Given this list of marker genes Pikfyve, Dnajc2, Gcc2 (NCBI Gene Id 76266), Lpp, Ets1, Me2, Cnpy2, Txlna, Nr4a2, Shkbp1, Nectin1, Nolc1, Psmd12, Rad23a, Cdc37l1, Psmb2, Ankhd1, Bcl2l1, Fryl, Baz2b, Aktip, Zbtb11, Csnk1a1, Mydgf, Dzip1, Hdac4, Wasf2, Tjp2, Id2, Dnajb11, Notch1, Ptprj, Septin10, Ctbp1, Slc8a1 (NCBI Gene Id 319418), Psmc4, L3hypdh, Llph, Dis3, Plet1, Prr13, Cemip2, Krt19, Gata2, H4c8, Dnajc1, Nucks1, Bcl7a, Ptgfrn, Trim8, Tbc1d17, Mettl3, Dek, Rnd3, Cspg5, Zfp704, Tax1bp1, Elovl5, Hnrnpa0, Chd1, Plin3 (perilipin 3), Tob2, Rfwd3, Slc39a10, Col23a1, Oard1, Gm5176, H4c1, Id1, Cd2bp2, Ldb2, Pde3a, Rsrc1, St13, Camk1d, Upk2, Hcfc1r1, Upk3a, Aamp, Kdm3b, Oxct1, Chd4, Atp5me, Psmd2, App, Trim17, Uxs1, Map7d1, Ncor1, Emc1 (ER membrane protein complex subunit 1), Sipa1l2, Gon4l, Dhx36, Sfpq, Fam171a2 (family with sequence similarity 171, member A2), Tnks1bp1 (tankyrase 1 binding protein 1), Hypk, Zfp462, Nav1, Golim4, Wnk1, Mgst3, Arid5b, Zfp937, Sp6, Timp2, Ndufa4, Furin, Septin9, Litaf, Zbtb14, Snw1, Sox9, Aph1a, Phf13, Dctn4, Fat4, Vps36, Arhgef2, Lactb, Gigyf2, Ube2i, Alyref, Ptk7, Bckdha, Orai3, Sptbn1, H2ac18, Dusp7, Aftph, Dnmt1, Nlgn3, Rbms3, Cldnd1, Glmp, Lima1 (LIM domain and actin binding 1), Rnf111, Tbc1d16, Gpd2, Nrip1, Ciao2a, Pkp4, Bcl9, Fras1, Sart1, Gnai2 (G protein subunit alpha i2), Parva, Ly6h, Nfia, Pfdn2, Ptpn11, Phb1 (prohibitin 1), Micu2, Epha7, Hgs, Fgfr1op2, Smtnl2, Gadd45g (growth arrest and DNA-damage-inducible 45 gamma), Bclaf1, Cyp2f2, Klhdc10 (kelch domain containing 10, NCBI Gene Id 76788), Lrp1, Atad2b, Cdc27, H4c14, H3f5, Wwc1, Ppp4c, Dnmt3a, Cltc, Cldn7, Senp2, Dolpp1, Eif3j1 (NCBI Gene Id 98779), Gm4750, Nek7, Zmynd8, Scand1, Srsf9, Hspa8, Kbtbd2 (kelch repeat and BTB (POZ) domain containing 2), Ptms, Phkg2, Khdrbs3, Cald1, Tcf3, Tnrc6b, Smg6, Taf1, Phf6, Aldh1a1, Anxa9, Csrp1, Dync2i1, Rcor1, Wnt6, Gsr, Cuta, Ptges3, Ssh1, Ppil1, Derl1, Ablim1, Rest, Rangap1, Pfn1, Prrc2c (proline-rich coiled-coil 2C), Dpysl2, Ier5l, Hoxa13, Sap30, Slc38a10, Zfp664, Gria4, Kdm6b, Flnc, Kcnk1, BC048507, Itgb1, Set, Ppp2r5e, Rn18s-rs5, Atp1b1, Lratd2, Poldip3, Bsdc1, Trp53, Zfp110 (NCBI Gene Id 97420), Ptgr1, Prkcsh, Crim1, Triobp, Eif4a-ps4 (eukaryotic translation initiation factor 4A, pseudogene 4), Chpt1, Tlk1, Maged1, Adam17, Cxadr, Bahcc1, Zfp871, Fscn1, Sppl3, Rfx7, Pcdh18, Manf, Plcxd3, Nedd4, Nudt3, Klf3, Gsg1l, Pdzd2, Adamdec1, Pcnx3, Crebbp, Sin3b, Rhob, Dhx29, Tnrc6a, Arpc4, Kras, Hsd17b7, Aldh3b2, Rc3h2, H2ac4, Ubfd1, L3mbtl3, Nol8, Dazap1, Gpc1, Pabpn1, Clic4, Uhrf1, Bmp4, Hmg20b (high mobility group 20B), S1pr3, Wac, Vps54, Maco1, Arf3, Ago2, Septin7, Ywhae, H2aj, Ppp1ca, Sf3b2 (splicing factor 3b, subunit 2), Auts2, Pex5, Gtf2h3, Timm17b, Nufip2, Clptm1, Cdk14, Mia2, Kmt2c, Cdk2, Id3, Prrx1, Zc3h13, Cep170b, Rbm27, Mprip, Cables2, Btg1, Arhgdia (Rho GDP dissociation inhibitor alpha), Rnf122, Marchf7, Ncoa6, Shtn1, Dhrs3, AA986860 (expressed sequence AA986860), Ddx6, Canx, Zfp628, Sdf2l1, Dgcr2, Nfya, Ptprd, Ier3ip1, Dennd2b, Grn, Irf2bp2, Ing4, Pphln1, Ago1, Gipc1, Nasp, H4c16, Itgb5, Ecd, Hsp90b1, Akr7a5, B230219D22Rik (RIKEN cDNA B230219D22 gene), Ttc9c, Leprotl1, Skp1, Morf4l1, Chd9, H1f2, Cxxc1, Noc2l, Pkm, Gm5732, Sertad3, Sinhcaf, Pofut1, Fkbp4, Bltp2, Epcam, Pheta1, Snrpd3, Zfp644, Gm8807, Senp3, Mllt3, Smoc2, Ahnak, Uqcc2, Cnn2, Aff3, Snd1, Cd2ap, Dnlz, Ergic1, Sprr1a (small proline-rich protein 1A), Hmgcr, Tmed2, Lef1 (NCBI Gene Id 99641), Gm13140, Syt13, Mboat2, Gypc, Cdk5rap2, Mdfi, Eif4b, Krt8, Appbp2 (amyloid beta precursor protein binding protein 2), Ski, Bzw1, Cnot11, Zfp410, Pdia4, Rrp1, Pum1, Elavl1, Rab12, Tpm3, Psap, Daglb, Rbfox2, Ptov1, Kdelr2, Ppp1r37, Ccni, Tasor (transcription activation suppressor), Stk25, Samd5, 2510009E07Rik, Kif2a, Zfhx3, Lsp1, Smarca2, Strn3, Rwdd4a, Arid4a, Adnp2 (ADNP homeobox 2), Thrap3, Btbd2, Pabpc4l, Camk2n1, Clca1, Qrich1, Dynll2, Arhgap29, Calr (NCBI Gene Id 12317), Gata3, Kdm5d, Mnt, Gbf1, Taok1, Tfdp1, Casp7, Tm9sf1, Sertad2, Golph3, Tbc1d10a, Phldb2, H1f5, Myo1b, Hnrnpu, Vangl2, Med25, Gm8756, Ubap2l, Cbx4, Cat, Golga4, Adipor1, Enpep, Ilf3, Rps19, Sympk (NCBI Gene Id 68996), Hnrnpc, Brd4, Tet2, Kansl1, Ubr2, Naa30, Lzts2, Nfix (NCBI Gene Id 18032), Gspt1, Tiam1, Pdzd8, H1f4, Ppp4r3a, Plagl2, Snrnp70, Myocd, Bcl2l12, Tcf20, Mybbp1a, Abhd17c, B4galt2, Mgat1, Zhx1, Snrpf, Tmem132a, Vapa, Palld, Mycl, Spr, Nrep, Hoxd13, Foxn3, Mov10, Inhba, Arhgap10, here is a description of the gene set: from publication Schaeffer EM, Marchionni L, Huang Z, Simons B, Blackman A, Yu W, Parmigiani G, Berman DM (PMID 18794802) Cancer cells differentiate along specific lineages that largely determine their clinical and biologic behavior. Distinct cancer phenotypes from different cells and organs likely result from unique gene expression repertoires established in the embryo and maintained after malignant transformation. We used comprehensive gene expression analysis to examine this concept in the prostate, an organ with a tractable developmental program and a high propensity for cancer. We focused on gene expression in the murine prostate rudiment at three time points during the first 48 h of exposure to androgen, which initiates proliferation and invasion of prostate epithelial buds into surrounding urogenital sinus mesenchyme. Here, we show that androgen exposure regulates genes previously implicated in prostate carcinogenesis comprising pathways for the phosphatase and tensin homolog (PTEN), fibroblast growth factor (FGF)/mitogen-activated protein kinase (MAPK), and Wnt signaling along with cellular programs regulating such 'hallmarks' of cancer as angiogenesis, apoptosis, migration and proliferation. We found statistically significant evidence for novel androgen-induced gene regulation events that establish and/or maintain prostate cell fate. These include modulation of gene expression through microRNAs, expression of specific transcription factors, and regulation of their predicted targets. By querying public gene expression databases from other tissues, we found that rather than generally characterizing androgen exposure or epithelial budding, the early prostate development program more closely resembles the program for human prostate cancer. Most importantly, early androgen-regulated genes and functional themes associated with prostate development were highly enriched in contrasts between increasingly lethal forms of prostate cancer, confirming a 'reactivation' of embryonic pathways for proliferation and invasion in prostate cancer progression. Among the genes with the most significant links to the development and cancer, we highlight coordinate induction of the transcription factor Sox9 and suppression of the proapoptotic phospholipid-binding protein Annexin A1 that link early prostate development to early prostate carcinogenesis. These results credential early prostate development as a reliable and valid model system for the investigation of genes and pathways that drive prostate cancer. Mouse Gene Set: SCHAEFFER_PROSTATE_DEVELOPMENT_6HR_DN Genes down-regulated in the urogenital sinus (UGS) of day E16 females exposed to the androgen dihydrotestosterone for 6 h. species: Mus musculus